Given this list of marker genes ECHDC3, LINC00710, SFTA1P, LINC02642, SFMBT2, PRPF38AP1, LINC02648, GATA3, PROSER2-AS1, LINC02676, CHCHD3P1, RNA5SP299 (RNA, 5S ribosomal pseudogene 299), USP6NL, RNU6-88P, KRT8P37, LINC02670, RNU6-1095P, TAF3 (TATA-box binding protein associated factor 3), PROSER2, UPF2, ITIH2, LINC02663, ENSG00000287277, ORMDL1P1, COX6CP17, CELF2-AS1, ITIH5, RNU6-535P, MIR548AK, KIN, NUDT5, CELF2, CDC123, CUX2P1, CELF2-DT, LINC00709, USP6NL-AS1, ENSG00000271046, ATP5F1C, SEC61A2, DHTKD1, GATA3-AS1, CELF2-AS2, LINP1 (lncRNA in non-homologous end joining pathway 1), ENSG00000228027, ELOCP3 (NCBI Gene Id 649647), LINC00706, ENSG00000308117, LINC02665, LINC00708, HSP90AB7P, here is a description of the gene set: studied in species Homo sapiens Human Gene Set: chr10p14